The following is a description of a gene set: Genes down-regulated in LSK cells (bone marrow) as a function of a QTL for the size of hematopoietic stem cell (HSC) population: comparison of congenic D.B. Chr 3 (DB, small HSC population) vs parental D2 strain (huge HSC population). Human Gene Set: LIANG_HEMATOPOIESIS_STEM_CELL_NUMBER_SMALL_VS_HUGE_DN species: Mus musculus We mapped quantitative trait loci that accounted for the variation in hematopoietic stem cell (HSC) numbers between young adult C57BL/6 (B6) and DBA/2 (D2) mice. In reciprocal chromosome 3 congenic mice, introgressed D2 alleles increased HSC numbers owing to enhanced proliferation and self-renewal and reduced apoptosis, whereas B6 alleles had the opposite effects. Using oligonucleotide arrays, real-time PCR and protein blots, we identified latexin (Lxn), a gene whose differential transcription and expression was associated with the allelic differences. Expression was inversely correlated with the number of HSCs; therefore, ectopic expression of Lxn using a retroviral vector decreased stem cell population size. We identified clusters of SNPs upstream of the Lxn transcriptional start site, at least two of which are associated with potential binding sites for transcription factors regulating stem cells. Thus, promoter polymorphisms between the B6 and D2 alleles may affect Lxn gene expression and consequently influence the population size of hematopoietic stem cells. from publication Liang Y, Jansen M, Aronow B, Geiger H, Van Zant G (PMID 17220891), and this is the list of marker genes: GADD45B, CEP89, SLC9B2, NPTX1, PDCD7, COTL1, PTTG1, ATP2A3, NRSN1, SAP18, SOCS2, APC, ACSM3, DOK2, C4orf3, POLG2, RRAGD, RAG2, HS1BP3, MCM3, RASGRP2 (RAS guanyl releasing protein 2), S100A6, CD1D, DNAJA1 (NCBI Gene Id 4737), SERPINI1, WDR45B, TRAM1, S100A4, MAPK8, WDTC1, CYTH1, TUBA1A, WDR48